The following is a description of a gene set: species: Mus musculus Mouse Gene Set: chr18C, and this is the list of marker genes: Mospd4 (motile sperm domain containing 4), Pggt1b, Ccdc112, Gm4146, 4930415P13Rik, Gm26262, Ticam2, Gm3734, Gm16283, Gm6883, Gm5839, Lvrn (laeverin), Atg12, Fem1c, Tmed7, Gm41720, Trim36, A330093E20Rik, 1700044K03Rik, Eif1a, Eno1b, Gm5237, Gm4840, Hspe1-rs1, Gm5095, Arl14epl, Gm49974, 1700018A14Rik, Cdo1, G630055G22Rik, A430019L02Rik, Ap3s1, Gm22791, Dtwd2, Gm18993, 9130209A04Rik, Sema6a, Gm3744, Gm3720, Commd10, Gm5236, Gm8468, Gm4107